The following is a description of a gene set: Human Gene Set: GOMF_ESTROGEN_RESPONSE_ELEMENT_BINDING Binding to an estrogen response element (ERE), a conserved sequence found in the promoters of genes whose expression is regulated in response to estrogen. studied in species Homo sapiens, and this is the list of marker genes: ESRRB, NR3C2, TRIM24, ESRRG, PGR, ESR1, ESR2, AR, ESRRA (NCBI Gene Id 2101), NR3C1, NR6A1